The following is a description of a gene set: Human Gene Set: GSE42021_CD24INT_VS_CD24LOW_TCONV_THYMUS_UP species: Homo sapiens from publication Toker A, Engelbert D, Garg G, Polansky JK, Floess S, Miyao T, Baron U, Düber S, Geffers R, Giehr P, Schallenberg S, Kretschmer K, Olek S, Walter J, Weiss S, Hori S, Hamann A, Huehn J (PMID 23420886) We investigated at which stage of maturation commitment to a stable Foxp3-expressing phenotype takes place. We assessed stability of Foxp3 expression in thymic Foxp3+ Treg subsets of different maturity, defined by CD24 expression. Next we compared gene expression profiles of Foxp3+ Treg subsets (+) of different maturity (24lo, 24int, 24hi) and could identify a set of genes that were specifically up or downregulated in Foxp3+ Tregs, but not in Foxp3- conventional T cells, in a maturation-dependent manner. Genes up-regulated in thymic T conv: CD24 int versus CD24 low., and this is the list of marker genes: BATF3, WARS1, MAPK10 (NCBI Gene Id 5602), SMIM10L1, CKM, CIR1, VPREB1, DIO1, SIMC1P1, PRKACG, PGM5, CLPX, MAP6D1, FERRY3, ACSL4, TEAD4, PSMB8, PTPN1, ITK, CDC42EP4, PI15, MMP10, CDKN2AIP, RMND1, TNFAIP2, BNIP2 (BCL2 interacting protein 2), KLF4, SLC52A1, SCN9A, RARS1, APOL3, APOL6, MFSD1, PRAMEF11, IL6ST, TXNL4B, MYOZ1, SQOR, APOL2, IL10RB, C3, IGFLR1, ARHGAP29, CEBPB, MS4A4A, RALGDS, LDLR, RPS6KA2, CBX2, ARID5B, SIN3B, TRAFD1, LINC02249 (long intergenic non-protein coding RNA 2249), DRAM1, FOSL2, TRPM3, ENTREP2, TLX1, GTF2B, TMEM231, APLNR, CREM, PSMB10, GSAP, IL15RA, ATP10D, IL32, PCDHB6, C5orf15, CADPS, RABGAP1L, ZNF318, FRMD4B, MBD4, DENND4A, TP73, DNAJC12, CFHR2, ZNF330, CCDC68, USP24, JAK2, HK1, REEP1 (NCBI Gene Id 65055), APOL1, SSX1, C1orf21, GCH1, ABCB11, MAST1, PIM1, GCLM, IRF1, ICAM1, IL7, ARFGAP3, CEP162, ZFP36, FMOD, DPYD, GUK1, OR10H3, IDO1, ITPKC, FAS, NFASC, SETX, LMX1B, EDN2, PYGM, CYB5A, LIFR, MORC3, LEPROTL1, KRTAP5-8, INPP5E, CTSL, MTHFD2, CXCL5, CXCL9, RIPK2, TRPC6, BHLHE40, BAK1, SOD2, LHCGR (NCBI Gene Id 3973), THAP11, ARL4D, KCTD2, KIF2A, ARHGAP24, CLCA3P, PCGF1, POLR3D, CASP7, SUSD6, BCL3, CEBPD, CTR9, CRYGC, TENT5C, UBE2L6, RBM4, ADGRG3, MCUB (NCBI Gene Id 55013), AHCYL2, ZNF200, PHKB, STAT3, CTSS, INO80D, GABARAPL1, H3C11, DDX23, HSPA6, MAPK7, CFH (NCBI Gene Id 3076), HLA-E, TAF1B, CD47, KIF18A, IFI30, SEMA3F, MFAP1, TP53BP2, IL1R1, CCL2, CXCL2, IRF8, GNL3, MSRB1, SAMD4A, CISH, CDIPT, SMCO4, ATP6V1B2, SOCS1, CSRP1, SEPHS2, VRTN, NDST2, GAS1, SECTM1, HOXA7, DGKQ, CMAHP, GSTK1, PROZ, GCNT3, ANXA2P3, ZNF22, LAP3, MAFF, NTRK1, CAND2, PSMB9, TMEM121, IL15, CSH2